Given this list of marker genes CNTNAP3B, HOXD8, MFSD4A, TMEM252-DT, TSPEAR, EFCC1, ADGRG3, MPP7, HOXD10, STAB2, P4HA3, CCL21, LINC02880, PARD6G, FLT4, TSPAN8, LINC01117, GPR182, TBX1, CMKLR2, GPR146, ZNF24TR, PGM5-AS1, HOXD9, LINC02147, TNFAIP8L3, FZD10, ANKRD36BP2, PIK3C2G, ENSG00000233358, LINC00636, SPHK1 (NCBI Gene Id 8877), C20orf204, ADD3-AS1, PTX3, TFF3, NTS, C6orf141, HOXD4, LINC02840, PROX1-AS1, PROX1, ABCA4, SLC38A4, here is a description of the gene set: Human Gene Set: DESCARTES_FETAL_HEART_LYMPHATIC_ENDOTHELIAL_CELLS studied in species Homo sapiens The gene expression program underlying the specification of human cell types is of fundamental interest. The study authors generated human cell atlases of gene expression and chromatin accessibility in fetal tissues. For gene expression, the study authors applied three-level combinatorial indexing to >110 samples representing 15 organs, ultimately profiling ~4 million single cells. The study authors leveraged the literature and other atlases to identify and annotate hundreds of cell types and subtypes, both within and across tissues. Our analyses focused on organ-specific specializations of broadly distributed cell types (such as blood, endothelial, and epithelial), sites of fetal erythropoiesis (which notably included the adrenal gland), and integration with mouse developmental atlases (such as conserved specification of blood cells). These data represent a rich resource for the exploration of in vivo human gene expression in diverse tissues and cell types. Marker genes curated from the annotated cluster as represented in the Descartes Human Gene Expression During Development database. from publication Cao J, O'Day DR, Pliner HA, Kingsley PD, Deng M, Daza RM, Zager MA, Aldinger KA, Blecher-Gonen R, Zhang F, Spielmann M, Palis J, Doherty D, Steemers FJ, Glass IA, Trapnell C, Shendure J (PMID 33184181)